Given this list of marker genes Smarca1, H1f10, H2az1, Rnf168, Nap1l4 (nucleosome assembly protein 1-like 4), Mllt6, Hmgn2, Pwwp3a (PWWP domain containing 3A, DNA repair factor), Parp2, Smarca5, Ssrp1, L3mbtl1, Hmga2, H1f8, Znhit1, Noc2l, Ezh2, Eed, H3f3b, Cgas, H1f9, Hmgn3, Chd1l, Arid1a, Hira, Rnf169, H1f6, Parp1, H1f3, H3f3a, H1f2, Hmgn5, Arid1b, H3f5, Ezh1, H1f0, H1f5, Sap30l, Mllt10, Sirt6, Hp1bp3, Cabin1, Rcc1, H1f1, Glyr1, Supt16, Dnttip1, Actr6, Supt6, Macroh2a1, Rnf4, H1f4, Vrk1, Hmgn1, here is a description of the gene set: studied in species Mus musculus Mouse Gene Set: GOMF_NUCLEOSOME_BINDING Binding to a nucleosome, a complex comprised of DNA wound around a multisubunit core and associated proteins, which forms the primary packing unit of DNA into higher order structures.